Given this list of marker genes Exosc7, Exosc6, Exosc8 (exosome component 8), Exosc4, Exosc2, Exosc9, Exosc3 (NCBI Gene Id 66362), Exosc5, here is a description of the gene set: Mouse Gene Set: GOBP_U4_SNRNA_3_END_PROCESSING studied in species Mus musculus Any process involved in forming the mature 3' end of a U4 snRNA molecule.